Given this list of marker genes MTND4LP32, ENSG00000286477, CCNJP1, TRIM60P16, BSNDP4, ENSG00000234089, CCT6A, CICP11, CICP28, MTCO3P10, SNORA15, PHKG1P4 (phosphorylase kinase catalytic subunit gamma 1 pseudogene 4), MTND2P6, SEPTIN14, SEC61G-DT, MTATP6P8, IFITM3P4, CHCHD2, MTND6P29, NCOR1P3, SUMO2P3, LINC02854, MTND5P7, MIR3147, MRPS17, ZNF716, MTND4P4, MTCO1P10 (NCBI Gene Id 107075140), TNRC18P3, VSTM2A, RNU6-1335P, VOPP1-DT, SUMF2 (sulfatase modifying factor 2), RNU6-1126P, SLC25A5P3, MTATP6P10, MTCYBP5, RPL31P35, VSTM2A-OT1, RNU6-1125P, EGFR-AS1, LINC01445, MTCO2P10, SEPTIN7P15, NMD3P2, MTCYBP29, MTND5P6, RBM22P3, NUPR2, VN1R25P, SNORA22B, CICP12, PSPH, CDC42P2, RNU7-157P, RNU6-1052P, EGFR, MTND1P4 (NCBI Gene Id 100873171), NIPSNAP2, ELDR (EGFR long non-coding downstream RNA), MIR3147HG, SLC29A4P1, ENSG00000233288, LANCL2, CALM1P2, GUSBP12, VOPP1, PSPHP1, RNU6-389P, CICP8, MIR4283-1, PHKG1, ENSG00000228735, ENSG00000287517, FKBP9P1, ZNF713 (NCBI Gene Id 349075), GUSBP10, MTCO3P4, GPCPD1P1, ZNF479, VN1R28P, MTND4P5, SEC61G, SAPCD2P2, SEPTIN14P24, TUBBP6, ENSG00000303536, ENSG00000291021, here is a description of the gene set: Human Gene Set: chr7p11 species: Homo sapiens